The following is a description of a gene set: Combining with an odorant and transmitting the signal from one side of the membrane to the other to initiate a change in cell activity in response to detection of smell. Mouse Gene Set: GOMF_OLFACTORY_RECEPTOR_ACTIVITY studied in species Mus musculus, and this is the list of marker genes: Or51a42, Or10aa1, Or8b3b, Or7g19, Or13c7d, Or7g17, Or5w1, Or10h1b, Or6c210, Or2at4, Or4f60, Or14j6, Or14j4, Or8b39, Or13c7, Or4e1, Or56b35, Or13a18, Or13p3, Or4z4, Or8g37, Or5d16, Or7g22, Or2w1b, Or5m13b, Or51i1, Or8g28, Gm7582, Or2y16, Or2i1, Or1f12, Or10d4c, Or56b1b, Or5bw2, Or10am5, Or51b17, Or7e170, Or14j10, Or8u9, Or8b48, Or13d1, Or5j3, Or51k1, Or11n2, Or7g34, Or4f62, Or8s16, Or11q2, Or6k6, Or5a21, Or8g26, Or2g7, Or8k22, Or6d13, Or51l14, Or8d2, Or51a10 (NCBI Gene Id 258326), Or5m9b, Or9i14, Or4c115, Or1x6, Or4m1, Or52s1b, Or56a3, Or4c3d, Or11l3, Or2c1, Or2y10, Or4f4-ps1, Or10j2, Or7g21, Or4l15, Or13e8, Or5b102, Or8g17, Or4x15, Or2ag15, Or4f14c, Or52ab2, Or5p76, Or2y1, Or6c66, Or2ag1b, Or4c10b, Or2t26, Or5p78, Or6c211, Or9i16, Or5w17, Or4c119, Or5g25, Or6c5c, Or8b46, Or4c105, Or5g27, Or8k17, Or2ag2b, Or5an9, Or12d14-ps1, Or5m3, Or5b101, Or6b9, Or5h22, Or6b2, Or2d36, Or5d37, Or1j13, Or2h1, Or13a19, Or1aa2, Or14p1 (NCBI Gene Id 258419), Or2ab1, Or4f17-ps1, Or8h9, Or4a39, Or8d4, Or52ab4, Or10ag57, Or13a26, Or2y12, Or5w19, Or4k45, Or52e18, Or7g32, Or7h8, Or4k48, Or51ag1, Or4k52, Vmn2r4, Or10q1 (NCBI Gene Id 258992), Or14j5, Or10v1, Or11g7, Or5b117 (NCBI Gene Id 258685), Or8b4 (olfactory receptor family 8 subfamily B member 4), Or3a1b, Gucy2d, Or4c12b, Or5d36, Or5p51, Or4d2b, Or2a12, Or51b6b, Or4k35, Or7e173, Or8b36, Or1e16, Or51f1, Or1n1, Or6c5, Or8b54, Or2d4 (olfactory receptor family 2 subfamily D member 4), Or7r1, Or4n5, Or4a76, Vmn2r82, Or10j7, Or3a4, Or4p23, Or52ad1, Or52h7, Or2t45, Or7a35, Or6c75, Or8b101, Or9r3, Or10ag54, Or6c213, Or5t18 (olfactory receptor family 5 subfamily T member 18), Or1j20, Or4f7, Or2b7, Or12e7, Or2b28, Or6c6b, Or52b3, Or5m12, Or13c7b, Or4f15, Or6c217, Or8b3, Or11g26, Or11h7, Or5k16, Or51s1, Or52r1, Or7e177, Or5w16, Or1l4, Or6c8 (NCBI Gene Id 434709), Or51f23, Or5h27, Or8c13, Vmn2r3, Or5w15, Or8k35, Or5aq1, Or52n2c, Or5ak4, Or2l5, Or12e10, Or4k37, Or55b10, Or6c208, Or4c113, Or3a1c, Or9s14, Or5k3, Or6c212, Or10g3, Or8k33, Or14j1 (olfactory receptor family 14 subfamily J member 1), Or5an10, Or6c68, Or52z15, Or9g4, Or51v8, Or52z13, Or5w14, Or55b3, Or2t46, Or7g20, Or2n1d, Or8c18, Or7e178, Vmn2r81, Or2w2, Or9k2b, Or2p2, Or2m13, Or12e9, Or2v2, Or51m1, Or51r1, Or4f4b, Or8c11, Or6b3, Or1e19, Or10w3, Or2a51, Or6c214, Or9s27, Or5p6, Or56b1, Or5b94, Or4d10b, Or2ag16, Or6c33, Or2n1c, Or51ai2, Or10x1, Or7g18, Or1e34, Or4k49, Or2ag13, Or6c209, Or10ak11, Or14j2, Or5m11b, Or2g1, Or5g9, Or5al7, Or2ag1, Or2o1, Or10d5, Or13f5, Or9g10, Or12j5, Or2ak4, Or56a5, Or2f1b, Or11h6, Or13a24, Or10s1, Or4k15b, Or8c20, Or2t29, Or8s8, Or12k7, Or13c7c, Or9s15 (olfactory receptor family 9 subfamily S member 15), Or2w3b, Or8k28, Or7g28, Or14a258, Or9q2, Or6c216, Or51aa5, Or5d20-ps1, Or1o2, Or4p21 (olfactory receptor family 4 subfamily P member 21), Or10ad1c, Or10d5j, Or13g1, Or5af2, Or1j8, Or8b43, Or2w6, Or5b107, Vmn2r26, Or5ac19, Or5b116, Or10g1b, Or1j12, Or2z2, Or5p79, Or52z14, Or12d17, Or8c9, Or5k1b, Or10ag59, Or4k5, Or6c7, Or6c219, Or8s5, Or6c205, Or5p4, Or6s1, Or5h23, Or10g9b, Or4f47, Or10j3b, Or5an1c, Or6c207, Or51b4, Or9g8, Or4a67, Or7d10, Or51h1, Or2aj5, Or4c3, Or52a33, Or52a5, Or13a20, Or2y1b (olfactory receptor family 2 subfamily Y member 1B), Or8g35, Or10x4, Or10g7, Or5ac24, Or5p56, Or8g33, Or5a1, Or2v1, Or4a79, Or5ap2, Or8g20, Or11h23, Or5an6, Or5p57, Or4c101, Or1j14, Or5m5, Or6c65, Or6k8-ps1, Or7g26, Or5p54, Or14a257, Or10a5, Or8g19, Or52b4i, Or10c1, Or5a3, Or10p22, Or2ak6 (olfactory receptor family 2 subfamily AK member 6), Or12e13, Or6c3, Or11h4, Or4c31, Or52s19, Or2n1b, Or52n5, Or4c99, Or2a54, Or6z3, Or1ad8, Or10a48, Olfr363-ps, Or5as1, Or51af1, Or1o4, Or8u8, Or4d10c, Or2r2, Or4c120, Or4b1, Or10ab5, Or4k1, Or4d5, Or4c100, Or7a42, Or10g1, Or8b38, Or5p62, Or5v1, Or5o1, Or8g27, Or8b41, Or5ae1, Or5k15, Or52e8b, Or8c15, Or2ag2, Or1a1, Or8k27, Or2b11, Or4g7, Or52n3, Or5ak25, Or12d12, Or6c69b, Or8g54, Or1e22, Or3a1d, Or2q1 (NCBI Gene Id 258437), Or2ag17, Or56b2j, Or10u4, Or6e1, Or4c110, Or52h2, Vmn2r2, Or5al5, Or14a260, Or8s2, Or5an1, Or6c38, Or1j19, Or5d38, Or4d1, Or12j4, Or2y11, Or8b47, Or4g16, Or8g51, Or7e174, Or4c11, Or8b12, Or5h26, Or6b2b, Or1m1, Or4a27, Or4k39, Or1j18, Or12j3, Or8b57, Or52l1, Or4a15, Or5k1, Or2b6, Or6f2, Or5aq6, Or52d3, Or4k47, Or51a39, Or10g9, Or5p63, Or6c88, Or10ak16, Or2y8, Or10ag52, Or2a25, Or4c15, Or14c41, Or13a27, Or9a2, Or5m9, Or51aa2 (NCBI Gene Id 632917), Or52h9, Or51ab3, Or5b124, Or12k8, Or4c125, Or7g23, Or4c117, Or8j3c, Or8b12b, Or5p70, Or3a10, Or52e5, Or1j17, Or2t44, Or10aa3 (olfactory receptor family 10 subfamily AA member 3), Or4f58, Or6c69, Or4c29, Or2w1, Or2m12, Or5ac22, Or4a81, Or4a78, Or1e29, Or2w3, Or2bd2, Vmn2r120, Or9i1b, Or52e15, Or8b1b, Or9e1, Or2y1e, Or10d3, Or8g52, Or13a21, Or6p1, Or8g23, Or8b51, Or14c43, Or10ak9, Or5ac20, Or2h2c, Or1f19, Vmn2r83, Or2z9, Or5b12b, Or51g1, Or1j11, Or8g50, Or7a39, Or4c111, Or1x2, Or2d3c, Or4c11b, Gm7609, Or10a3n, Or12d2, Or7g27, Or10ac1, Or4p4, Or5b108, Or5d35, Or1e1f, Or7e176 (olfactory receptor family 7 subfamily E member 176), Or13a1, Or10q3, Or13p5, Or6c2, Or10ak13, Or7a40, Or2a7, Or9r7, Or8k1 (NCBI Gene Id 258575), Or4f57, Or8c10, Or12e8, Or10ak7, Or6f1, Or1e35, Or8h8, Or4a72, Or5w20, Or5d47, Or4c124, Or51f1d, Or1af1, Or8c8, Or4k38, Or52n2b, Or11g27, Or2r3, Or8g2, Or5b99 (olfactory receptor family 5 subfamily B member 99), Or9g19, Or5m10b, Or2y1d, Or52e19b, Or2t35, Or9m2, Or8b1d (NCBI Gene Id 258781), Or14c44, Or8g2b, Vmn2r6, Or56b6, Or9m1, Or8b35, Or6c35, Or4c52, Or1j1, Or6k2, Or51a7, Or52e3, Or10al7, Or8b12c, Or52n4b, Or52e7, Or1p1c, Or2aa1, Or4b12, Or8k38, Or4x11, Or52e4, Or4k15, Or10ak12, Or6c1, Or6c69c, Or5e1 (olfactory receptor family 5 subfamily E member 1), Or4c10, Or10d1b, Or6c76b, Or2ah1, Or13a22, Or7g16, Or4a71, Or7e175, Or8k3b, Or7g25, Or2ag20, Or4c118, Or5b21, Or10g3b, Or11g24, Vmn2r65, Or6z6, Or7e165, Or4a66, Or6aa1, Or5b12, Or13n4, Or5bh3, Vmn2r5, Or2ag18, Or5w18, Or5aq7, Or56a3b, Or52ae9, Or5p72, Or2j3, Or4a77, Or1e1, Or7g35, Or8k18, Or4a69, Or51k2, Or1e23, Or5b98, Or8k20 (olfactory receptor family 8 subfamily K member 20), Or4c106, Or4k40, Or8b53, Or5k17, Or4p8, Or51f1e, Or2y1g, Or6ae1, Or10d4, Or8g4, Or6c6c, Or2f2, Or5d43, Or8k40, Or52ab7, Or14c45, Or4d2, Or6c1b (olfactory receptor family 6 subfamily C member 1B), Or14c39, Or6c8b, Or5w13 (NCBI Gene Id 258653), Or5t16, Or2aj4, Or9i1, Or5b118, Or2k2, Or4p22, Or5ak23, Or10al4, Or5b3, Or10ak14, Or10z1, Or5aq1b, Or10h28, Or2t47, Or5b105, Or5af1, Or1n2, Or13l2, Or5d46, Or6z5, Or51d1, Or52n2, Or5bb10, Or4f54 (NCBI Gene Id 258389), Or6b1, Or1d2, Or8k3, Or52s1, Or52d1, Or10a3b, Or52r1c, Or1o3, Or5t15, Or9m1b, Or8k24, Or10q12, Or2l13b, Or8i2, Or5d18, Or5p55, Or1l8, Or5p61, Or4f61, Or2g25, Or5t17, Or9i2, Or4c1, Or8g30, Or5p64, Or4c121 (NCBI Gene Id 258969), Or5an1b, Or5d45, Or1ad6, Or1e1c, Or13p10 (NCBI Gene Id 258312), Or13ae2, Or5b109, Or12j2, Or12e1, Vmn2r7, Or2w25, Gm15433, Or9s13, Or5b112, Or51q1c, Or51l4, Or10ag60, Or6y1, Or8s10, Or8b8, Or6c203, Or4f6 (NCBI Gene Id 258441), Or5b106, Or8a1b (olfactory receptor family 8 subfamily A member 1B), Or10j3, Or2h2, Or8b40, Or4p20, Or5ac23, Or6d12, Or14a256, Or6c76, Or4n4, Or10b1, Or10ak8 (NCBI Gene Id 258214), Or7a37 (NCBI Gene Id 259044), Or10q1b, Or2y6, Or8g34, Or2h15 (NCBI Gene Id 435547), Or2a14, Or4f53, Or2a52, Or7a41, Or6d14, Or51h5, Or8g53, Or8b49, Or4q3, Or10ag58, Or2d3b, Or5h17, Or5v1b, Or12d15, Or52s6, Or4c108, Or6b13, Or10ad1, Or4c123, Or6b6, Or4c102, Or4c107, Or9s18, Or5h19, Olfr1060-ps1, Or5au1, Or4c35, Or10al3, Or8k30, Or10ag53, Or4n4b (NCBI Gene Id 258657), Or12d13, Or51e2, Or1j4, Or4p7, Or5k14, Or52k2, Or52z12, Or5w22, Or6z7, Or8g55, Or10v5, Or6n1, Or10d4b, Or4s2, Or7g29 (olfactory receptor family 7 subfamily G member 29), Or4k2, Or51a25, Or5j1, Or5ac16, Or52h1, Or14j9, Or4a2, Or7g12, Or4a74, Or5d14, Or2ad1, Or2b2b, Or4f14b, Or2ag19, Or2y13, Or5c1 (NCBI Gene Id 258371), Or4d10, Or1ad1, Or2aj6, Or8k25 (olfactory receptor family 8 subfamily K member 25), Or4e2, Or52r1b, Or4b1c, Or52e2, Or5h25, Or2a57 (NCBI Gene Id 258367, olfactory receptor family 2 subfamily A member 57), Or52m2 (NCBI Gene Id 257684), Or51v14, Or2n1e, Or1a1b, Or5p58, Or56b2, Or2t49, Or1ak2, Or11a4, Or52p2, Or52b2 (olfactory receptor family 52 subfamily B member 2), Or55b4, Or5b122, Or6c215, Or8d23, Or51ah3, Or6k4, Or8g24, Or4c11c, Or7c70, Or5p68, Or4a70, Or9g20, Or4e5, Or10ah1-ps1, Or2w4, Or8b42, Or2n1, Or6c200-ps1, Or13a25, Or4k77, Or6c70, Or14j7 (NCBI Gene Id 383243), Or5p60, Or5ac15, Or8d1, Or2a56, Or11j4, Or4c127, Or5l14, Or51i2, Or5b104, Or6n2, Or8b56, Or4a73, Or5p53, Or51p1, Or7g30, Or52a24, Or51f5, Or52e8, Or5b96, Or52d13, Or4f14d, Or6d15 (NCBI Gene Id 258438), Or10j5 (olfactory receptor family 10 subfamily J member 5), Or2r11, Or2a5, Or51q1, Or5w8, Or1s2, Or8g36, Or5al6, Or1b1, Or51k7, Or9s23, Or4k41 (NCBI Gene Id 257935), Or10ab4, Olfr908, Or4f56, Or52n4, Or5w12, Or5b95, Or2ak7, Or8g32, Or6c206, Or6x1 (olfactory receptor family 6 subfamily X member 1), Or9g3, Or52z1, Or5g26, Or4x6, Or2f1, Or52p1, Or4b13, Or5ac17, Or10d1, Or1e25, Or7a36, Or8h6, Or8g18, Or8a1, Or56b34, Or1q1, Or5bb12, Or51a5, Or5w10 (olfactory receptor family 5 subfamily W member 10), Or5b113, Or7e168, Or2ak5, Or2t6, Or13p4, Or4c109, Or14a259, Or4c12 (NCBI Gene Id 258338), Or1e32, Or4k15c, Or4p18, Or8b1c (olfactory receptor family 8 subfamily B member 1C), Or5m10, Or8h10, Or5b121, Or2z8 (NCBI Gene Id 404315), Or8u3-ps, Or5b24, Or52j3, Or51ac3, Or4d11, Or51a6, Or6c201, Or1l4b, Or5b97, Or10ag56, Or4a68, Or5k8, Or52n20, Or4c112, Or2y3, Or8h7, Or51t4, Or9a4, Or5p5c-ps1, Or4f59, Or4p19, Or5m8, Or5d39, Or6c74, Or10a2, Or5al1, Or8b50, Or52w1, Or5d40, Or4c126, Or51f2, Or12k5, Or10w1, Or5b123, Or5p81, Or8c16, Or52x1, Or1j10, Or5m3b, Or5g23, Or10h1, Or5ak22, Or4c114, Or56a4, Or8j3, Or8d2b, Or5b111, Or2d2b, Or2a20, Or8b37, Or11i1 (olfactory receptor family 11 subfamily I member 1), Or52n1, Or7a38, Or1o1, Or5an11, Or5p52, Or51a24, Or52b4, Or52a5b, Or5m13, Or1j21, Or8k41, Or11h4b, Or5p59, Or8c17, Or52m1, Or10u3, Or4a47, Or4g17, Or4s2b, Or10p1, Or1e21, Or5d3, Or2y15, Or6c66b, Or9g4b, Or51e1, Or2b4, Or4c15b, Or4k51 (NCBI Gene Id 258889), Or5ae2 (NCBI Gene Id 258410), Or1r1, Or13a28, Or7d9, Or1e30, Or7g33, Or1i2, Or14c46, Or52ae7, Or10j27, Or5ac21, Or3a1, Or5l13, Or6c202, Or8b1, Or4k6, Or9q1, Or12d16-ps1, Or10al5, Or6c3b, Or5w11, Or5i1, Or5ar1, Or10al6, Or10p21, Or11g2, Or4x13, Or7e169, Or5p50, Vmn2r1, Or8g21, Or13a17, Or4b1b, Or2y14, Or10g6, Or11g1, Or4k44, Or5d41, Or8g22, Or6k14, Or6c5b, Or10n1, Or6c2b (olfactory receptor family 6 subfamily C member 2B), Or13j1, Or8k32, Or7e166 (NCBI Gene Id 257963), Or52a20, Or52b1, Or7d11, Or10v9, Or1j16, Or10al2, Or5t7, Or6c204, Or5ak20, Or10ad1b, Or4k36, Or1e31, Or13c3, Or5d44, Or4a75 (NCBI Gene Id 258787), Or8k23 (olfactory receptor family 8 subfamily K member 23), Or10ag2, Or13c25, Or2h1b, Or5w1b, Or9a7, Or6z1, Or4l1, Or4c122 (NCBI Gene Id 258973), Or5t9, Or6a2, Or8u10, Or5h24, Or51f23b, Or8d1b, Or10a4, Or7c19, Or5ac25, Or10k2, Or8b9, Or6c6, Or2av9 (NCBI Gene Id 257932), Or8k37, Or4b1d, Or10a3m, Or2at1, Or5b120, Or2y1f, Or51a43, Or8b52, Or51a8 (olfactory receptor family 51 subfamily A member 8), Or2d2, Or52e19, Or8b44, Or1o11, Or5g29, Or8j3b, Or4a80, Or52u1, Or2y1c, Or14c40, Or52i2, Or11m3, Or8b12i (NCBI Gene Id 57251), Or10d1c, Or14j8 (NCBI Gene Id 258094), Or7g31, Or2b2, Or4c104, Or13p8, Or5be3, Or1e17, Or4c58, Or5p1, 4930516K23Rik, Or5t5, Or4c103, Or5h18, Or2l13, Or1n1b, Or6c63-ps1, Or2d3, Or1ab2, Or51b6 (olfactory receptor family 51 subfamily B member 6), Or2ag12, Or11g25, Or8b55, Or56a41, Or1e33, Or5p66, Or1p1, Or2t43, Or10h5, Or5p5, Or2t48, Or4c116, Or8k39, Or4k42, Or5ak24, Or2j6, Or1e26 (olfactory receptor family 1 subfamily E member 26), Or1j15, Or5p67, Or4f52 (NCBI Gene Id 257980), Or5p73, Or2t1 (NCBI Gene Id 259029), Or8k53, Or5b119, Or5p80, Or9k7, Or14j3, Or51g2, Or9k2, Or4d6, Or10a49, Or52ac1, Or2y17 (NCBI Gene Id 259068), Or8d6, Or8w1, Or4f14, Or5p69, Or10a3, Or12e14, Or8k16